The following is a description of a gene set: part of: Toll Like Receptor 3 (TLR3) Cascade species: Homo sapiens In human, together with ubiquitin-conjugating E2-type enzymes UBC13 and UEV1A (also known as UBE2V1), TRAF6 catalyses Lys63-linked ubiquitination. It is believed that auto polyubiquitination and oligomerization of TRAF6 is followed by binding the ubiquitin receptors of TAB2 or TAB3 (TAK1 binding protein 2 and 3), which stimulates phosphorylation and activation of TGF beta-activated kinase 1(TAK1).<p>TAK1 phosphorylates IKK alpha and IKK beta, which in turn phosphorylate NF-kB inhibitors - IkB and eventually results in IkB degradation and NF-kB translocation to the nucleus. Also TAK1 mediates JNK and p38 MAP kinases activation by phosphorylating MKK4/7 and MKK3/6 respectivly resulting in the activation of many transcription factors. <p>The role of TRAF6 is somewhat controversial and probably cell type specific. TRAF6 autoubiquitination was found to be dispensable for TRAF6 function to activate TAK1 pathway. These findings are consistent with the new mechanism of TRAF6-mediated NF-kB activation that was suggested by Xia et al. (2009). TRAF6 generates unanchored Lys63-linked polyubiquitin chains that bind to the regulatory subunits of TAK1 (TAB2 or TAB3) and IKK(NEMO), leading to the activation of the kinases.<p> Xia et al. (2009) demonstrated in vitro that unlike polyubiquitin chains covalently attached to TRAF6 or IRAK, TAB2 and NEMO-associated ubiquitin chains were found to be unanchored and susceptible to N-terminal ubiquitin cleavage. Only K63-linked polyubiquitin chains, but not monomeric ubiquitin, activated TAK1 in a dose-dependent manner. Optimal activation of the IKK complex was achieved using ubiquitin polymers containing both K48 and K63 linkages.<p>Furthermore, the authors proposed that the TAK1 complexes might be brougt in close proximity by binding several TAB2/3 to a single polyubiquitin chain to facilitate TAK1 kinase trans-phosphorylation. Alternativly, the possibility that polyUb binding promotes allosteric activation of TAK1 complex should be considered. Reactome Pathway: TICAM1,TRAF6-dependent induction of TAK1 complex, and this is the list of marker genes: UBB, UBC, UBA52, TAB3, TAB1, RPS27A, TRAF6, TAB2, MAP3K7, TICAM1, TLR3